The following is a description of a gene set: Mouse Gene Set: GOBP_POSITIVE_REGULATION_OF_MULTICELLULAR_ORGANISMAL_PROCESS species: Mus musculus Any process that activates or increases the frequency, rate or extent of an organismal process, any of the processes pertinent to the function of an organism above the cellular level; includes the integrated processes of tissues and organs., and this is the list of marker genes: Usp22, Slc7a1, Irak1, Ccm2l, Bcl10, Il1rl1, Nr1h4, Clec4n, Ccl1 (NCBI Gene Id 373502), Ccr1l1, Lpar3, Bcl6, Heg1, Syde1, Ccn1, Spry1, Nptn, Trim27, Nlrp1a, Edn2, Rad21, Mmp9, Slc9a1, Jag1, Cd5, Nfatc4, Egf, Gjc2, Hmces, Icos, Prkca, Clec7a, Itpka, Lpl (NCBI Gene Id 16956), Adora2a, Pck1, Mir155, Ngfr, Cck, Notch2, Adgrb2, Ephb1, Prl3d2, Cd74, Musk, Prdm16, Spi1, Kcnq1, Srebf2, Serpinf2, Ccnb1, Arhgef2 (Rho/Rac guanine nucleotide exchange factor 2), Nrg1, Il17ra, H2-DMb1, Zfp609, Trip10, Nod1, Ighm, Pdgfb, Cnot3, Ifi203-ps, Pdgfrb, Tnfsf13, Tspo, Il36g, Il9, Tlr5, Agt, Lrrtm4, Irgm1, Ache, Srf, Uts2r, Adrb3, Mup20 (major urinary protein 20), Lrp2, Lacc1, Ceacam20, Tnf, Actr2, Cxcl12, Anxa2, Smarcd1, Serpinf1, Acvrl1, Tmprss12, Plxnb3, Mef2c, Clec12a, Tafa3, Zfyve27, Cyld, Hspa5, Irf1, Tert, Actb, Wnt2, Ffar4, Itgax, Id4, Tgfbr1, Fcgr2b (Fc receptor, IgG, low affinity IIb), Fam20c, Prkaa1, Numa1, Adrb2, Gpld1, Slc20a2, Mfn1, Postn, Chodl, Kl, Clic3 (chloride intracellular channel 3), Ptgis (prostaglandin I2 (prostacyclin) synthase), Agtr1b, Tppp, Adipoq, Ticam2, Rbbp4, Bex1 (brain expressed X-linked 1), Btg1, Ascl1, Ksr2, Ifnar1, Ncl, Fgf1, Prl7b1, Bcl7a, Il15ra, Ptpn22, Prkce, Scn3b, Nos3 (nitric oxide synthase 3, endothelial cell), Kdm6b, Cyp19a1, Trak1, Stat5a, Vps35, Prkd1, Arid4b, Runx2, Plag1, C1qtnf4, Tnfrsf11a, Dhx58, Fcgr3, Psen1, Tslp, Oas3, Lhx1, Ncam1, Il4i1, Ephb4, Epha4, Zfp516 (zinc finger protein 516), Prl4a1, Sod1, C3, Zfpm1, Nppc, Setd2, Ffar3, Hlx, Prg2, Cd4, Eif2ak3, Efnb3, Zbtb20, Hdac2, Avpr2, Jund (NCBI Gene Id 16478), Tiam1, Ffar2 (free fatty acid receptor 2), Gdf5, Plxnc1, Asxl2, Cd40lg, Vegfa, Ddx1, Usp2, Axin2, Brd7, Tfrc, Mir23b, Klhl25, Tpm1, Ins2, Cd6, Adgrl4, Fgf3, Mmp14, Stk25, Hipk2, Stau2, C1qbp, Rab7b, Dhx33, Nfkbid, Faah, Ucp1, Atp5pf, Map3k7, Ptn, Macf1, Fermt1, Anxa1, Serp1, Six4, Rapgef4, Cebpg, Cxcr2, Btn2a2, Jmjd8, Tigit, Crlf2, Pth2r, Cask, Cd36, Notch4 (NCBI Gene Id 224712), Aif1, Sting1, Bmp2, Sptbn1, Suds3, Tnfrsf1a, Batf, Gnas, Zbed3, Nlrp3, Sema5a, Tob2 (transducer of ERBB2, 2), Adcyap1, Sash1, Zc3h12a, Ppp2r3c, Hsph1, Tnfsf11, Lrtm2, Ccnd1, Sptbn4, Rif1 (replication timing regulatory factor 1), Syk (NCBI Gene Id 20963, spleen tyrosine kinase), Smarcb1, H2-M3, Mlh1, Lpin1, Gsdma3, Tbx2, Carmil2, Angptl3, Nlgn3, Rtn4, Adam8, Prpf19, Polr3d, Hmox1, Zfp365, Pou4f2 (POU domain, class 4, transcription factor 2), Foxg1, Nodal, Hmgcr (3-hydroxy-3-methylglutaryl-Coenzyme A reductase), Clec5a, Brms1, Pax8, Clec9a, Tut4, Disc1, Lrtm1, Ace2, C1qtnf3, Arfgef2, Sox15 (SRY (sex determining region Y)-box 15), Lrrn3, Ghr, Spx, Ikzf1, Grip1, Fzd4, Lyn, Cacng1, Atraid, Hras, Ppib, Kpna2, Flt1, Car2, Plcg2, Zeb2, Sox8, Myrf, Flt3l, Cyba, Ltbp3, Panx1, Il21, Flrt3, Shb, Agap2, Lrrtm2, Map2k1, Ptger2, Wnt11, Smurf1, Gata5, Pcid2, Cd55, Hk1, Creb1, Elovl6, Adam7, Cftr, Dcx, Pak4, Fgf8, Flt4, Ihh, Avpr1b, Hes1, Dppa1, Xcl1, Hrc, Ager, Ybx2, Fbxw8, Sox13, Fgfbp3, Prl7c1, Camk2d, Pdpk1 (3-phosphoinositide dependent protein kinase 1), Hc, Cblb, Il13, Sct, Bmp1, Npnt, Nck2, Lum, Sphk2, Htr2b, Hspa1b, Arrdc4, Csf1r, Itpkb, Il17c, Atf2, Wt1, Fst, Hmgb1, Rims2, Aspm, Adra2c, Il20rb, Lef1, Cd84, Gfi1b, Rack1, Lgals9 (NCBI Gene Id 16859), Stk11, Klre1, Gba1, Ccl4, Grin2a, Bmpr1a, Grem1, Ccr5, Zbtb7b, Kcnn4, Macroh2a1, Acvr1b, Sfxn5, Zbtb16, Atp2b1, Sinhcaf, Tsku, Nkx6-1, Zp3, Btnl2, Smarcc1, Ccl3, Erap1, Igf2, Tead3, H2-Eb2, Alms1, Dusp5, Dsg2, Bin1, Itga2, Gp1bb, Dhps (NCBI Gene Id 330817), Il17a, Sox2, Prkab1, P2ry1, Pak1, Clcf1, Spta1, Adm, Retn, Gdf2, Ror2, Adra2b, Trp73, Atpsckmt, Fgfr3, Pim1, Shank3, Stra6, Ocstamp, Tmem106a, Scx, Bcl3, Il4ra, Lif, Thy1, Fabp5, Nap1l1, Cyp2j6, Cd101, Pawr, Kat2a, Zbtb46, Nlgn2, Ccl19, Il20, Rxrb, Rhoa, Ddx3x, Rpl4, Rxfp4, Pls1, Myog, Ncoa2, Gbp4, Prl7a2, Map6 (microtubule-associated protein 6), Nr5a1, Htr2a, Pou1f1, Yap1, Pdcl3, Lrrk2, Cd83, Actr3, Timd6, Slc22a21, Ccl21a, Cux2, Prl3a1, Nog, Eif4g2 (eukaryotic translation initiation factor 4, gamma 2), Il23a, Runx3, Kars1, Il6ra, Slamf1, Ltb (NCBI Gene Id 16994), Src, Lcn2, Dio2, Tank, Celf1, Phf10, Tnfsf14, Sfrp2, Sgms1os1, Fadd, Mapk11, Foxp3, Ccl2, Chrnb2, Plat, Phox2b, Cd40, Pex5l, Gal, Timd5, Oas1f, Tacr1, Hoxd11, Pou4f1, Vegfb, Mir326, Slc39a12, Crabp2, S100b, Gria1, Nkx3-1, Atp8a2, Myf6, Tlr3 (toll-like receptor 3), Twf1, Mtm1, Stat5b, Pnp2, Osr1, Caprin2, Prlr, Prl8a8, Krt17, Slc9b2, Rel, Lgals8, Grid2, Abl1, Ttpa, Gprc5b, Ebf2, Msh2, Chil5, Adgrl3, Cd320, Gp5, Bag1, Tox, Irf5, Ptger4, Nr1h2, Emilin2, Ccl24, Gsk3a, Wwtr1, Il1rap, Npy1r, Cpt2, Skint1, Arx, Fcgr1, Negr1, Por, Pik3r6, Nod2, Brca1, Dmrta2 (NCBI Gene Id 242620), Ezr, Trim32, Lilra5, Nkx2-2, Nppa, Fgr, Tmed10, Pax6, Smad1, Prkdc, Hey2 (hairy/enhancer-of-split related with YRPW motif 2), Dpf2, Il1r1, Xbp1, Epas1, Smo, Dixdc1, Slc4a1, Thbs1, Ccbe1, Sp1 (trans-acting transcription factor 1), Gpr183, Iqgap3 (IQ motif containing GTPase activating protein 3), Pin1, Oas1a, Cul7, Ly9 (lymphocyte antigen 9), Prkg2, Tgfbr3, Inhba, Ptafr, Bmp4, Cyfip1, Pla2g4a, Ptprf, Adgrv1, Chia1, Bcl7b, Nrxn1, Decr1, Npr3, Tfap2a (transcription factor AP-2, alpha), Mtnr1b, Bbs4, Sox6, Ctnnb1, Letmd1, Flot2, Prl5a1, Hspb6, Ifi206, Tnfsf15, Fcer1a (NCBI Gene Id 14125), Cdk9, Alox12b, Vim, Nmb, Scube2 (signal peptide, CUB domain, EGF-like 2), Lamtor5 (late endosomal/lysosomal adaptor, MAPK and MTOR activator 5), Slc39a10, Adm2, Srrt, Mmp12, Prl2c2, Cckbr (cholecystokinin B receptor), Cdk18, Igf1r, Shld3, Cux1, Map1lc3b, Eno1, B4galt5, Pdcd1lg2, Hrh2, Panx2, Nos2, Tnfrsf8, Enpp4, Dll3, Mir143, Il12b, Megf8, Npas2, Bst1, Nkx6-2, Acta2, Gimap3, Shox2, Irf3, Nmnat1, Cd81, Alx1, Inava, Traf3ip3, Jak2, Smarce1, Ets1, Rps6ka1, Tlr9, Zfpm2, Hdac3, Gli1, Pde9a, Chrnb4, Il2ra, Slc27a1, Ldlrap1, Foxp1 (NCBI Gene Id 73231), C3ar1, Naip5, Prl2c5 (NCBI Gene Id 53971), Mapk13, Lgr4, Tnfsf9, Spint1, Timd2, Asic2, Ptgs1, Atp1a1, Smarcd2, Atad5, Oas1g, Ankrd42, Traf3, Sec1, Pla2r1, Angpt1, Havcr2, Plg, Penk, Fdps, Igf1, Mir23a, Efna5, Klf10, Sash3, Il17f, Evi2, Cntnap2, Kiss1, Dkk1, Smarcc2, Bloc1s3, Ifi214, Tgfb3, Frmd8, Stoml2, Gpm6b, Tlr4, Cdk1, Stat3, Oprm1, Sphk1, Epo, Abcc8, Ncoa3, Sh3kbp1, C1qtnf1 (NCBI Gene Id 72004), Prkcz, Prap1, Lrp1, Tbx5, Tescl, Dbn1, Ephb2, Ghrh, Lrp6, Adgrb1, Cpb2, Scrib, Rock2, Islr2, Bmper, Thra, Snap91, Ehmt1, Sln, Arid5a, Ep300, Fzd5, Tnfsf4, Tnik (TRAF2 and NCK interacting kinase), Klrk1, Cd209b, Crh, Ccl11 (NCBI Gene Id 20292), Galr1, Itga5, Cyp2j5, Smtn, Vil1 (villin 1), Fgfr1, Ifngr1, Cdh5, Bscl2, Tgfb1, Ccr1 (C-C motif chemokine receptor 1), Itgb3, Vtcn1, Nfatc3, Amigo3, Il3, Fcnb (NCBI Gene Id 14134), Wnt4, Hdac4, Pkdcc, Tnfsf18, Ppargc1a, Pqbp1, Aqp1, Mir124a-3, Gja1, Def8, Lingo4, Gapdhrt, Cd1d1, Lilrb4b, Oprk1, Grin2b, Ap3d1, Tarm1, Sdcbp, Il33, Acvr2a (NCBI Gene Id 11480), Mydgf, Il1a, Prkch, Cebpb, Gbp5, Cd209c, Gsx2, Irs2, Prl8a1, Cacnb1, Clstn2, Foxa2, Slc7a5, Flot1, Cfap20, Polr3f, Vsir, G0s2, Ddah1, Lrrc4b, Klf6, Mme, Rasgrp1, Scn5a, Rela, Ghrhr, Acacb, Fh1, Stat6, Ccl9, Brd4, Slc6a3 (NCBI Gene Id 13162), Malt1, Dio3, P2ry2, Itch, F3, Blm, Dll1, Isg15, Notch1, Clstn1, Fxr2, C5ar1, Dync1h1, Acat2 (NCBI Gene Id 21456), Nectin2, Camk2b, Nfam1, Hoxa11, Ace, Csf1 (colony stimulating factor 1 (macrophage), NCBI Gene Id 97111), Oas2, Ucn, Il27, Prl3d3, Cx3cr1, Sox5, Dpp4, Ephb6, Ccl5, Cd209e, Prkcq, Ulbp1, Exosc6, Slc11a1, Atg7, Slitrk5, Myf5, Sema3a, Grm5, Cst7, Hyal1, Ccr2, Ankrd27, Jade2, Ereg, Apoe, Dag1, Itgam, Rara, Agpat1, Vash2, Il2rg, Irf8, Kmt5c, Osm, Oas1b, Prl2c3, Lrg1, Rb1, Hspb1, Baiap2, Pkm, Wls, Gch1, Pnp, Thbs2, Wdr35, Nps, L1cam, Atxn1, Adra2a, Xiap, Pycard, Cmklr1, Tent5a, Hmgb2, Rufy3, Lipg, Tshr, Zbtb1, Ahsg, Sirpa, Ephb3, Ntsr1, Ryr2, Drd1, Rbbp7, F2rl1, Cacnb2, Rassf10, Mir214, Sart1, Sytl2, Tcf7l2, Card11, Nlrp10, Pparg, Foxa3, Ube2v2, Robo1, Dlg5, Adgrl2, Foxs1, Tjp1, Mavs, Il12rb1, Afdn, Mir223, Oxt, Tbc1d23, Afap1l2, Aspa, Ngf (NCBI Gene Id 18049), Golga4, Smad7, Lpcat3, Egr3, Mir27a, Ptprj, Eno1b, Aplnr, Crhr2, Stim1, Rftn1, Zfp488, Nlrp9b, Coro1a, Esrrb, Bcl9l, Amot, Smad2, Appl1, Nme2, Mif (NCBI Gene Id 17319), Dgat1, Rheb, Xrcc5, Sorl1, Il36a, H2-T23, Mir27b, Prl3b1, Ss18l1, Ptprz1, Foxl2, Vegfd, Trp63, Bmp7 (NCBI Gene Id 12162), Nlrp4f, Nckap1l, Traf2, Ddr2, Rhob, Pdpn, Hax1, Gp1ba, Ido1, Prox1, App, Cd226, Fcho1, Rnf112, Casp4, Rag1, Hcar2, Pde4d, Cbfb, Gsn, Grn (granulin), Pax2, Cd3e, Cyp8b1, Mapk14, H2-DMb2, Riok3, Smtnl1, Plcb1, Shtn1, Ptprd, Cnmd, Mir21a, Ss18, Etv4, Prl2a1, Gja5, Adra1b, Pias2, Slitrk2, Inhbb, Rest, Trpm8, Parp6, Mef2a, Slitrk1, Ghrl, Eeig1, Tbx21, Ddx21, Cyp1b1 (NCBI Gene Id 13078), Emc10, Dab2, Svep1, Nr2c2, Myc, Fxn (frataxin), Gata3 (GATA binding protein 3), Per2, Prg3, Trib1, Bmi1, Fermt2, Mndal, Hgf, Adgrl1, Pde5a, Trpc3, Slitrk4, Nfkbiz, Kmt5b, Tyrobp, Pten, Txk, Ogt, Il17rc, Slc8a1, Gp9 (NCBI Gene Id 54368), Il7r, Il1rapl1, Peli1, Gdf6, Rapgef3, Akap5, Fmr1, Ap3b1, Rgs2, Ppp3ca, Golga2, Sirt1, Mgll, Btk, Apc, Polr3a, Anxa3, Dhx9, Adora3, Mir103-1, Itgb1, Ucp2, Cma1, F2r, Cacna1c, Atp11c, Prdx2, Olig2, Bmpr1b, Clec4e, Cip2a, Pik3r1, Polr3b, Mia3, Slamf6, Dlk1, Elane, Agtr2, Id2, Fabp4, Tnfrsf13c, Itgb2l, Clu, Hrg, Spp1, Oas1d, Irf7, Nrdc, Myocd, Adgre5, Zfp580 (NCBI Gene Id 68992), Ing1, Zcchc3, Park7, Ret, Rab1a, Tlr6, Pxn, Nmbr, Ccl20, Ninj1, Fcna, Clcn2, Tomm70a, Plau, Lrrn1, Pex5, Pms2, Cd244a, Cd300lb, H2-Ob, Hoxc11, Add3, Foxc1, Mst1, Adam17, Casr, Traf6, Il1rl2, Msx2, Hmga2, Polr3g, Foxn1, Gsk3b (NCBI Gene Id 98033), Bbs2, Pth, Dcstamp, Dlg4, Tgfbr2, Cd300c2, Abat, Ccn2, Col1a1, Actl6a, Braf, Mrtfb, Ilk, Il23r, Myo5b, Parp2, Scimp, Abca1, Alb, Pard3, Stmp1, Zc3hav1 (zinc finger CCCH type, antiviral 1), Dnm1l, Bicral, Lck, Rps6kb1, Bloc1s6, Abl2, Raet1d, Nlrp1b, Cd274, S100a9, Edn1, Ar (NCBI Gene Id 11835), Plxnb1, H2-Ea, Sema4a, Gapdh-ps15, Ppp1cc, Ifi203, E2f1, Zfp322a, Irak3, Rgcc, Cbln2, Eif2b2, Il18r1, Fgf21 (fibroblast growth factor 21), Lepr, Tbxas1, Nlrp5, Parp1, Sulf2, Pmch, Cd28, Pdcd6, Mfap2, Hrh1, Map1b (NCBI Gene Id 268696), Hadh, Phb1, Ovol2, Mymk (myomaker, myoblast fusion factor), Vav1, Gapdhrt2, Mcoln2, Cadm1, Gsdmd, Smad6, Il15 (NCBI Gene Id 16168), Plpp6, Prl8a9, Fgfr2, Actn3, Ntrk1, Kdm1a, Tesc, Mkks, Wnt1, Ddrgk1, Tbx20, Tgm2, Tek, Ano6, Chd7 (NCBI Gene Id 57137), Prl3c1, Gpam, Ccdc88b, Twf2, Bmpr2, Sox10, Ptpra, Sox12, Erbb4, Oas1c, Apela, Ppargc1b, Flrt1, Tle6, Atp2a1, Bsg, Tbxa2r (NCBI Gene Id 21390), Xrcc4, Bambi, Rfx3, Chuk, Sh3pxd2b, Ccr3, Arhgap32, Ripk1, Avpr1a, Trpm4, Cd24a, Sgk1, Utp25, Lrrtm1, Prkcb, Trpv2, Oma1, Epx, Pagr1a, Nipbl, Otp, Akap12, Fos, Vdr, Lmod3, Cited2, Sap130, Drd2, Cd38, Ctsc, Mir124a-1, Pafah1b1, Psg22, Osr2, Smoc2, S100a1, Usp50, Zfp36l1, Ctsh, Grpr, Gpsm3, Ptger3, Gpr3, Wnt10b, Adam12, Cd86, Ptk2, Amigo1, Ptprc (protein tyrosine phosphatase receptor type C), Prl6a1, Tlr2, Map3k13, Mc1r, Card9, Ptpn11, Kpna2rt, Serpine2, Tespa1, Cd200, Gas6, Lgals1, Add1, Pou3f2, Faim, Smarca2, Selp, Myb, Nkx2-5, Mir124a-2, Fbn2, Ifi208, Nppb, F2, Cd55b, Flt3, Hamp2, Hpse, Ncmap, Msx1, Egr1, Htr2c, Kdm2b, Kit, Hilpda, Vkorc1 (vitamin K epoxide reductase complex, subunit 1), Crtam, Opa1, Synj1, Ing2, Casp1, Arid2, Unc13b, Fgf10, Agpat2 (1-acylglycerol-3-phosphate O-acyltransferase 2), Hdac6, Anapc2 (NCBI Gene Id 99152), Nlgn1, Sema4d, Akt1, Hyal2, Rims1, Alox5, Esrrg, Sirt6, Fgg, Spn, Nfatc2, Tac1, Ctf2, Cd209d, Angpt2, Tgfb2, Ifi207, Ifi209, Tbx1, Ifng, Plek, Mesp1, Fcer1g, Cx3cl1, G3bp1, Cd1d2, Mmp8, Tenm4, Grk2, Defb25, Isl1, Adipor1, Alpl, Ccn3 (NCBI Gene Id 18133), Nsd2, Lbh, Csf2, Evi2b, Shc1, Nin, Dlg1, Ece1, Chil4, Serpinb7, Tnfrsf1b, Jak1, Dennd1b, Pgf, H2-Aa, Xlr3b, Agrp (agouti related neuropeptide), Foxd1, Unc93b1, Tacr3, Nefl, Becn1, Acvr2b, Gata2, Chrm3, Itgb2, Cdkn1a, Rnd2, Adcy10, Fgb, Insl5, Rab8b, Hcrt, Il12rb2, Lyst, Cd27, Epha1, Mapk8, Prkci, Garin5a, Nkap, Cebpa (NCBI Gene Id 12606), Vegfc, Cacna1s, Il18, Bdnf, Gh, Gata4, Il12a, Lep, Mapt (microtubule-associated protein tau), Bhlhb9, Axl, Akt3, Dnaja3, Sox9, Fn1, Nell1, Polr3c, Nck1, Npy2r, Maged1, Selenok (selenoprotein K), Cd59b, Wnt3, Il2, Cysltr2, Adrb1, Oscar, Prl2c1, Tbc1d24, Star, Agtr1a, Bad, Nedd9, Nmu, Fzd3, Ptgs2, Optn, Kras, Tead1, Klhl22, Bmp10, Rbm19, Cib1, Bcl7c, Setd4, Chga, Fut1, Tead4, Cd2 (NCBI Gene Id 12481), Acadl, Plac8, Ezh2, Flrt2, Smad4, Fgfr4, Edn3, Rgs14, Dbnl, Hk2, Prkar1b (protein kinase, cAMP dependent regulatory, type I beta), Man2a1, Kdr (NCBI Gene Id 269657), Il17rb, Tet1 (NCBI Gene Id 70318), Thrb, Prkab2, Bcl2, Ctnnbip1, Cdkl5, Prl2b1, Tnr, Il10, Slc25a12, Prl7a1, Frs2, Apln, Npy, Egr2, Exosc3, Tnfrsf12a, H2-Oa, Slc30a1, Trp53bp1, Cxcl17, Tlr1, Gapdh, Adipor2, Iqsec1, Glmn, Trpc5, Fga, Efnb1, Wdr62, Smarca4, Prdm14, Pdgfc, Tnfsf13b, Il7, Ptk2b, Tmem64, Tlr7, Eif2s3y, Rigi, Erbb3, Elovl3, Prkd2, Uts2, Apoa2, Gpr68, Acvr1, Lrrc24 (leucine rich repeat containing 24), Nrp1, Oas1e, Khdc3 (KH domain containing 3, subcortical maternal complex member), Il6, Ikbke, Hdac1, Tnn, Alox12, Eng, Tiam2, Tcf3, Shld2, Ada, Enpp2, Camp, Kitl, Dct, Ghsr, Hand2, Stap1, Atp6ap2, Med1, Mpl, Vnn1, Ntrk2, Mir219a-1, Ago2, Itgal, Prl8a6, Sema7a, Igsf9b, Prl8a2, Numb, Laptm5, Ncoa1, Hspd1, Atg5, Sap30, Angpt4, Nox1, Kdm3a, Irf4, Pbrm1, Rbpj, Socs5, Xrcc2, Mc4r, Shld1, Cgas, Cd160, Smurf2, Trf, Akirin2, Dmrt1, Agrn, Vtn, Arnt, Adra1a, Kpna6, Myod1, Rab2b, Tmed10-ps, Snai1, Ly96, Mir219a-2, Mag, Vip, Bcl11a, Adra1d, Gdnf (glial cell line derived neurotrophic factor), Kat5, Trpv4, Trim6, Slit2, Clstn3, Vav3, Gper1, Pear1, Apoh, Ybx3, Stat1, Runx1, Sgip1, Jak3, Trim15 (NCBI Gene Id 69097), Arid1a, Cdh4, Kdm5b, Slc1a1, Lgals3, Tirap, Plekhm1, Sin3a, Brms1l, Met (NCBI Gene Id 194383), Ednrb, Metrn, Dusp10, Mecp2, Vcam1, Hsp90aa1, Emp2, Mad2l2, Prl3d1 (prolactin family 3, subfamily d, member 1), Enpp7, Caprin1, Mdk, Tgfb1i1, Lbp, Snx4, Ecm1, Numbl, Pde4b (NCBI Gene Id 97194), Atf4, Oas1h, Ecrg4, Ntrk3, Chil6, Mfn2, Mir875 (microRNA 875), Foxo3, Brd9, Tyk2 (NCBI Gene Id 54721), Scd1, Cdkl3 (NCBI Gene Id 213084), Fgf9, Mtor, Skil, Bmp6, Glipr2 (NCBI Gene Id 97132), Rgs4, B2m, Limk1 (LIM domain kinase 1), Stox1, Gatm, Nr4a3, Tlr8, Syndig1, Ntn1, Wars2, Rras, Ins1, Ist1, Cdon, Eif2ak2, Mir24-1, Tac4, Hamp, Cnr1, Kalrn, Dicer1, Srpx2, Vamp8, H2-Ab1, Rasal3 (RAS protein activator like 3), Nfe2l2, Ambra1, Rptor (regulatory associated protein of MTOR, complex 1), Plxnd1, Cxcr3, Grb10, Adnp, Fbxo31, Tnfrsf4, Smarcd3, Lingo2, Panx3, Gcnt2, Abca7, Sry, Trim65, Dhx37, Ufl1, Sh3glb1 (NCBI Gene Id 99782), Lrrfip2, Wnt5a, Snw1, D1Pas1, Gpr21, Hsf1, Foxj1, Nras, Fbxo38 (F-box protein 38), Rnf135, Pou2f2, Hap1, Adk, Cbln1, Itk, Ccnd2, Gdi1, Vstm5, Rhoh, Xrcc6, Gimap5, Gfap, Tmem119, Alox8, Picalm, Hps1, Il34, Iqsec2, Cela1, Cd46, Igfbp2, Avp, Ywhag, Il36b, Twist1, Rab21 (NCBI Gene Id 216344), Sap30l, Wnt3a, Cav1, Aim2, Reln, Appl2, Mir24-2, Pemt, Sulf1, Ttbk1, Rps3, Adgrb3, F12, Wasf3, Ednra, P2rx7, Clnk, Rsad2, Pkp1, Loxl2, Jcad, Tpbg, Mylk2, Wnk1, Egfr, Ndel1 (nudE neurodevelopment protein 1 like 1), Nr3c1, Prok2, Eef2k, Dbh, Rbm47, Tnip2, Cyp27b1, Olfm1, Trem2, Tusc2, Uap1, Marcks, Sox4, Pin1rt1, Apoa5, Il4, Ticam1, Zmiz1, Plcg1 (NCBI Gene Id 99130), Ifnb1, Ddit3, Cd47, Cd80, Arrb2, Klf4, Lurap1, Prl7d1, St3gal4, Arid4a, Fshb, Cd59a, Il6st, Gab1, Il1b, Tapt1, Fgf18, Casp8, Gata6, Aggf1, Icam1, Cartpt, Mbp, Klrh1, Vwf, Zfp335, Flna, Ighd, Smad3, Tradd, Sall1, Zfp703, Efnb2, Aire (autoimmune regulator), Pla2g3 (NCBI Gene Id 237625), Il16, Ramp2, Hoxb7, Mir103-2, Gpihbp1, Acin1, Ccr7, Clec4d, Prmt5, Nr5a2 (NCBI Gene Id 52226), Fcgr4, Neurl1a, Plxnb2, St8sia2, Inpp5d (inositol polyphosphate-5-phosphatase D), Dock8, Scamp5, Rps19, Itgb8, Myd88, Qki, Ccn4, Chrna7, Fes, Obsl1, Pdgfra, Bicra, Ifih1, Lrrtm3, Il5, Cd14, Foxc2, Slc25a4, Slitrk3, Socs1, Ripk2, Tnfrsf14, Rxra, Gadd45g, Pik3cd (phosphatidylinositol-4,5-bisphosphate 3-kinase catalytic subunit delta), Pibf1, Psen2, Mir324, Cttn, H2-Q7, Tie1, Cacna2d2, Lig4, Cyrib (CYFIP related Rac1 interactor B), Tbk1, Fzd9, Mmrn2, Ddx39b, Crb2, Ifi213, Brd2, Wnt7a, Akap6, Serpine1, F7, Etv5, Slitrk6, Mustn1, Mefv, Cybb, Hif1a, Dhx36, Actl6b, Ptpn1, Cxcr4, Chi3l1, Emilin1, Trim56, Rora, S100a13, Acsl1, Macroh2a2, Mtdh, Rock1, Amigo2, Spen, Tmf1, Inpp5k, Ell3, Ltf, Tacr2, Lilrb4a, Zap70, Havcr1, Slc22a5, Il27ra, Zfp219, Nr2e1 (nuclear receptor subfamily 2, group E, member 1), Chil3, Tmbim1, Mtpn, Rbfox2, Wnt2b, Il17d, Hnrnpk, Adora2b, Oxtr, Il17b, Cfl1, Fxr1, Map2k2, Robo2, Rufy4, Drd4, Cd276, Mapkapk2, Lta, Icosl, H2-Eb1, H2-DMa, Pak3, Rag2, Six1, Prl (prolactin), Hcls1, Jun, Mapk1, Spon2, Dscam, Paxip1, Sox11, Otx2, Lrp8, Mapk9, Cd34, Fgf2, Idua, Gli3, Ntf3, Grp, Cysltr1, Nlrc4, Capn3, Shh, Rreb1, Rnf10, Nkx2-2os, Jup, Pou2af1